Given this list of marker genes BDKRB1, KRTAP4-1, TRPV5, PNOC, CD40, CYP2B6, LCE2B, IGSF9B, ITGAM, LRP5, S100A9, HILPDA, ALPI (alkaline phosphatase, intestinal), DND1, KL (klotho), HSD17B2, CDKN1A, CCND1, KRTAP5-1, CEBPA, ORM1, SEMA3B, SLC34A2, KRTAP10-9, DEFB132, STS, IL25, COL13A1, CASP5, IRF5, KNG1, IGFBP5, KRTAP8-1, SLC8A1, TNFSF4, DEFB4A, LGALS9, CLDN2, LCE1F, IRF4, EFNA5, ALPG, CDC34, CDKAL1, IGFBP1, ID4, S100A6, HNF1A, S100A4, MYC, TREM1, S100A2, NFATC2, COLEC11, JUNB, SATB1, CDKN2D, TGFB1, ALOX5, ASAP2, ZNF257, NINJ1, CDK2, MXD1, CST6, KLF4, THBD, DACT2, CST1, LRRC25, SLC37A2, PRKCQ, PTGER4, KRTAP10-2, ID1, ABCD1, BTLA, MED9, CYP2C9, SFRP1 (NCBI Gene Id 6422), ADAMTS5, ATP2C2, CYP1A1, BMP6, CAMP, SULT2A1, SERPINB1, KRT16, KRTAP12-2, RASGRP1, CDKN2A, GADD45A, SALL4, HLA-DRB1, FOXO1, TIMP3, ADRB2 (adrenoceptor beta 2), PTH, STAM, CDX2, CD14, SULT1C2, KRTAP10-4, ORM2, CYP2S1, S100G, HIF1A (NCBI Gene Id 3091), BCL6, NOX1, CCNC, LCE1D, KLK6, CLPTM1L, ADRA1B, MX2, HLA-DQA2, CASP14, CLEC16A, DNER, TRPV6 (transient receptor potential cation channel subfamily V member 6), FGF23, CYP3A4, PPARD, CDKN2B, CRACR2B, LRRC8A, TNFSF11, CA9, TGFB2, BGLAP, TIMP2, CYP3A5, CCNE1, KRTAP5-4, TNFRSF11B, CYP24A1, SPP1, SOSTDC1, DEFB4B, CBS, SLC2A4, TNFAIP3, CDKN2C, G0S2, ADGRE5, EPHB4, CYP27B1, LPGAT1, S100A8, STEAP4, ABCA11P, CEACAM1 (NCBI Gene Id 634), ABCB1, IGFBP3, PTHLH, TPM1, IL1RL1, KRTAP10-7, GXYLT2, IL12A, TRAK1, KRT13, IRF8, KRT34, SPRR1B (small proline rich protein 1B), MYO9B (myosin IXB), PRDM1, CTLA4, RXRA, CYP2D6, NRIP1, KRT71, DUSP10, CYP7A1, KRT38, CDKN1B, ATP2B1, G6PD, VDR, CD9, HLA-DQA1, CLMN, CRACR2A, CREG2, CD200, here is a description of the gene set: Vitamin D receptor pathway Human Gene Set: WP_VITAMIN_D_RECEPTOR_PATHWAY studied in species Homo sapiens